The following is a description of a gene set: Genes predicted to be targets of miRBase v22 microRNA hsa-miR-4712-3p in miRDB v6.0 with MirTarget v4 prediction scores > 80 (high confidence targets). Human Gene Set: MIR4712_3P species: Homo sapiens from publication Chen Y, Wang X (PMID 31504780), and this is the list of marker genes: COX16, MLKL, MAPK9, GALNT13, NIPSNAP3B, TMEM35A (transmembrane protein 35A), ARIH1 (NCBI Gene Id 25820), SNTG1, LIPF, MID1, CD226, P2RY4, GAPT, ATXN10, RBM27, EDIL3, LCE5A, ACTR3C, TNRC6A, ZNF652 (zinc finger protein 652), OPRM1, FIBIN, ACVR1C, ADAM12, SLC7A14, RTL10, GPR158, CBR1, CRYBG3, FNDC7, SEC22B, CARD18, SLITRK3, BOD1L1, GPBP1, INSR, TMEM221, ZFYVE1 (NCBI Gene Id 57694), HIF3A, SYNJ2BP-COX16, TSPYL6, CBX6, UBE2E2, TRPS1 (transcriptional repressor GATA binding 1), IPO8, FAM120C, KIAA1671, GTF2A1, STEAP2, PHLDA1, ITPRID1, ZC2HC1A, NR1H4, DCAF8L1, NECTIN3 (nectin cell adhesion molecule 3), KRBOX4, C16orf46, HSPA12A, SORCS1, RFTN2, ATG12, BICC1, CEP44, AFAP1L2, OLFM4, ENSG00000255537, VEZT, ERCC6